The following is a description of a gene set: Ewing family tumors (EFTs) are small round blue cell tumors that show features of neuroectodermal differentiation. However, the histogenetic origin of EFTs is still a matter of debate. We used high-density DNA microarrays for the identification of EFT-specific gene expression profiles in comparison with normal tissues of diverse origin. We identified genes that are up-regulated in EFTs compared with normal tissues and validated expression of these genes in EFTs by both conventional and quantitative reverse transcription-polymerase chain reaction. The expression pattern of EFT-associated genes in normal tissues indicated a high similarity between EFTs and fetal and neuronal as well as endothelial tissues and supports the concept that a primitive neural crest-derived progenitor at the transition to mesenchymal and endothelial differentiation is transformed in EFTs. EFT-associated genes could be used for molecular discrimination between EFTs and other small round blue cell tumors and clearly identified a cell line (SK-N-MC) that was initially established as neuroblastoma as being an EFT. Ectopic expression of the EFT-specific EWS-FLI1 fusion protein in human embryonic kidney (HEK293) cells was not sufficient to induce the complete EFT-specific gene expression signature, suggesting that the EFT-specific gene expression profile is not just a consequence of EWS-FLI1 expression but depends on the histogenetic background of the EFT stem cell. Human Gene Set: STAEGE_EWING_FAMILY_TUMOR Genes up-regulated in Ewing family tumors (EFT) compared with normal bone marrow samples. studied in species Homo sapiens from publication Staege MS, Hutter C, Neumann I, Foja S, Hattenhorst UE, Hansen G, Afar D, Burdach SE (PMID 15548687), and this is the list of marker genes: NPY5R, PAPPA, JAK1, RNF141, LINGO1 (NCBI Gene Id 84894), SNHG1, CLEC11A, PCDH11X, FAM156A, NPY1R, CNMD, CCK, ZDHHC21, PRSS35, AMER2, MAGED4, ADRB3, KCNAB3, GDF10, UGT3A2, ARX (aristaless related homeobox), CYP26B1, KDSR, BHLHE22, DKK2, PCDH8, STEAP1, EGR2, ITM2A, BCL11B, CCND1, LIPI